Given this list of marker genes Taf9b, Rps27a, Ccna1, Taf4b, Taf10 (NCBI Gene Id 24075), Rpa1, Dyrk2, Blm, Taf7l, Top3a, Mapk14, Hus1, Brca1, Taf13, Mapkapk5, Tpx2, Taf8, Prkag3, Nuak1, Csnk2b, Tbp, Bard1, Cdk5, Dna2, Chek2, Taf12, Rad1, Taf7, Taf5, Rbbp8, Aurkb, Taf11, Supt16, Rfc3, Kat5, Mre11a, Ubb, Trp53, Taf6, Wrn, Mapk11, Prkag1, Taf15, Nbn, Taf1, Rad9a, here is a description of the gene set: species: Mus musculus Reactome Pathway: Regulation of TP53 Activity through Phosphorylation electronically inferred by orthology from the curated human pathway part of: Regulation of TP53 Activity This event has been computationally inferred from an event that has been demonstrated in another species.<p>The inference is based on the homology mapping from PANTHER. Briefly, reactions for which all involved PhysicalEntities (in input, output and catalyst) have a mapped orthologue/paralogue (for complexes at least 75% of components must have a mapping) are inferred to the other species.